Given this list of marker genes HAUS3, PSMA5, MYBL2, DCTN1, TUBA1A, E2F3, MNAT1, CCNB2, OBI1, PSMA1, CEP164, TP53, SSNA1, SEM1, PSMD2, TUBA1B, CDC25A, XPO1, PSMD6, AJUBA, TUBA3C, GTSE1, TUBGCP6, PPP2R2A, LIN54, ADRM1, PLK4, FBXL18 (NCBI Gene Id 80028), CPAP, PSMD13, ALMS1, CUL1, TUBB, TUBB2A, PSMA7, PSMB3, PSMD3, MZT2A, MIS18BP1, CKAP5, MZT2B, LCMT1, HMMR, TICRR, PLK1, MZT1, PSMC2, CDK11B, SFI1, UBA52, ODF2, CDC25C, LIN52, CEP290, CCNH, HSP90AA1, HAUS4, CEP135, RPS27A, BTRC, PSMA3, CCNA1, TUBB4A, RBBP4, CCNA2, TPX2, CLASP1, TUBB6, FBXW11, TUBGCP4, AURKA, PPP2R1B, BORA, HAUS6, TUBB8, LIN37, CDK1, TUBA3E, TUBG2, TUBGCP2, PSMC5, PPP2R1A, CEP72, PSMD1, CETN2, PSMA4, CEP131, HAUS8, TUBA3D, EP300, PSMC3, DCTN3, CEP250, YWHAE, AKAP9, CEP192, PPME1, RBX1, CCNB1, PPP1CB, HAUS1, SKP1, PSMB6, CEP43, PPP2CB, HAUS5, TUBA1C, PRKACA, CEP76, DYNC1H1, TUBA4B, TUBA4A, NINL, SGO1, TUBGCP3, WEE1, ACTR1A, NEK2 (NIMA related kinase 2), PSMC1, PRKAR2B, PSMB1, HAUS2, YWHAG, PSMD8, E2F1, PSMD14, LIN9, PPP1R12A, HJURP, NME7, PPP1R12B, DYNC1I2, CDK11A, PPP2R3B, CEP41, SDCCAG8, HAUS7, UBB, TUBB4B, TUBB8B, OPTN, PSMA6, DCTN2, CDK5RAP2, HSP90AB1, PCM1, TUBB3, CEP70, PSMD12, CEP63, CDK2, DYNLL1, CEP152, PHLDA1, NDE1, FBXL7, CDKN1A, CCP110, PSMC4, PPP2CA, FZR1, CDC25B, PSMD7, PSMB7, PCNT (NCBI Gene Id 9346), TUBAL3, FKBPL, UBC, CDK7, CSNK1D, FOXM1, NEDD1, CNTRL, PSMB2, PSMB5, MAPRE1, TUBG1, TUBGCP5, PAFAH1B1, CEP78, TUBB1, PSMC6, CSNK1E, TUBA8, RAB8A, OFD1, PSMD11, PSMB4, TUBB2B, PSMA2, CENPF, CEP57, PKMYT1, here is a description of the gene set: Reactome Pathway: Mitotic G2-G2/M phases part of: Cell Cycle, Mitotic Mitotic G2 (gap 2) phase is the second growth phase during eukaryotic mitotic cell cycle. G2 encompasses the interval between the completion of DNA synthesis and the beginning of mitosis. During G2, the cytoplasmic content of the cell increases. At G2/M transition, duplicated centrosomes mature and separate and CDK1:cyclin B complexes become active, setting the stage for spindle assembly and chromosome condensation that occur in the prophase of mitosis. studied in species Homo sapiens